Given this list of marker genes TSC1, NPRL3, TSC2, DEPDC5, MTOR (mechanistic target of rapamycin kinase), here is a description of the gene set: A type of focal cortical dysplasia that is characterized by disrupted cortical lamination and specific cytological abnormalities. Human Gene Set: HP_FOCAL_CORTICAL_DYSPLASIA_TYPE_II Focal cortical dysplasia type II species: Homo sapiens